Given this list of marker genes DGAT2L6 (diacylglycerol O-acyltransferase 2 like 6), LPGAT1, CRLS1, LPCAT3, PNPLA2, GPAT2, MOGAT3, LPCAT1, TAFAZZIN (NCBI Gene Id 6901), MOGAT1, LPCAT2, AWAT2, PNPLA3, LCLAT1, MBOAT2, DGAT2, AGPAT5, ABHD5, LPCAT4, AGPAT4, PNPLA4, AGPAT1 (NCBI Gene Id 84827), AGPAT2, GPAT4, MBOAT7, GPAT3, DGAT1, MBOAT1, MOGAT2, PLA2G15, AGPAT3, here is a description of the gene set: studied in species Homo sapiens Catalysis of the transfer of an acyl group to an oxygen atom on the acylglycerol molecule. Human Gene Set: GOMF_ACYLGLYCEROL_O_ACYLTRANSFERASE_ACTIVITY